Given this list of marker genes APC, UFD1, CHRNG, SYT2, DCHS1, NDUFB3, COA8, GLI3, INPP5E, YY1, COL25A1, MED12, SAMHD1, ANOS1, AFF4, RAD51C, SOX4, DPF2, ZNF423, GSN, CHRNE, SUFU, NDUFS7, RERE, PIBF1, SNAI2, ZFHX4, SLC6A8, MYCN, AIP, ATP5F1A, COMT, SLX4, MYO9A, HRAS, SLC25A1, TYMP (NCBI Gene Id 4334), CBY1, ZNF407, PDE4D, RAD51, RSPRY1, NDUFS2, MEN1, SMAD4, KIF11, SLC30A9, ARID1B, MT-TL1, RRAS, FILIP1, LSM11, TBCK, SECISBP2, TUBA1A, VAMP1, PDE6D, PEX3, COX10, ANXA11, PIEZO2, RPL8, MYMK, BCAS3, ADNP, TMEM107, JMJD1C, AARS1, DNM1 (NCBI Gene Id 1759), CNKSR2, SMC1A, AKT1 (NCBI Gene Id 207), TGIF1, TGFB2, TMEM67, KRAS, CAPN15, DGUOK, DIS3L2, FGF10, MECP2, CBL, NOTCH2NLC, PLCB4, SMARCC2, RPS28, SLC5A7, DALRD3, ADPRS, MPV17, TENM3, DHDDS, PSMD12, TET3, ANKRD11, GABRA5, CYC1, PUF60, COLQ, NIPBL, PARS2, GRIN2D, SMARCE1, KCNC2, NDUFV2, MAFB, GLE1, LMX1B, KCNA2, CDC42BPB, SLC3A1, YAP1, IREB2, OFD1, ABHD5, LMOD3, ZNF462, RFWD3, ATP1A2, SLCO2A1, RPS19 (NCBI Gene Id 8378), MRPS34, AGRN, PROK2, AUTS2, CAPRIN1, FBXO28, SLC12A6, BRCA1, PIGL (NCBI Gene Id 9487), PEX19, NOP56, PYROXD1, SQSTM1, RNU12, ISCU, HMGB3, CPLX1, FOXL2, KMT2B (NCBI Gene Id 9757), KIF21A, SPRY4, BRPF1, NDUFAF2, EP300, SCN1A, GATA1, NAA10, FGF17, RB1, SMARCA2, CPLANE1, TUBB2B, TWIST1, WDR35, SYNJ1 (NCBI Gene Id 8867), PEX12, GCK, PAX6, RPL15, FANCF, PRR12, FANCM, PUM1, MYH3, FGFR2, EDEM3, PRDX3, RNASEH2C, NFU1, FOXP1, MYF6, NDUFAF4, FANCB, DVL3, CTCF, FOXC2, SURF1, COLEC11, NDUFS1, PEPD, TIMMDC1, MID1, GABRB2, RILPL1, FANCD2, C1QBP, MAP2K1, TGFBR1, LZTR1, ZSWIM6, DHCR7, PDZD8 (PDZ domain containing 8), TBK1, PEX11B, SLC1A2, NTRK2, SALL4, SF3B4, TH, NDUFA6, HCN1, PHOX2B, IDS, ARID2, TBC1D2B, PIGQ, SMARCB1, WDR11, ODC1, NSD2, PPP3CA, IDUA, TMEM218, PEX10, CDC42, ITCH, CDH23, ARMC9, LONP1, SETD5, NSUN2, KIF1B (kinesin family member 1B), HACE1, TARDBP, MYL2, KATNIP, ATP5F1D, MICU1, RPS26, CELF2, IL17RD, UBE2T, GIPC1, GMPPA, ALX1, HPGD, SCN3A, WNT5A, SCN8A, EED, PPP1CB, ATPAF2, PTPN11, RBCK1, RASA2 (RAS p21 protein activator 2), LGI4, DUSP6, TCOF1, EXOC8, REV3L, TPM2, TACR3, RPL35, RREB1, FOXRED1 (FAD dependent oxidoreductase domain containing 1), DOK7, NDUFAF3, TMEM43, CSNK2A1, RIT1, CCDC141, TMCO1, KITLG, MAD2L2 (mitotic arrest deficient 2 like 2), RPL27, PROKR2, CCDC28B, PEX6, KIFBP, NDUFS8, TMEM138, SLC18A2, GATA3, SOX10, DDX59, MAPK1, SMS, IFT74, FOXC1, CHAT, SKI, ADAMTS15, KAT6A, TMEM126B, COL3A1, PEX2, RPS17, MINPP1, PHYH, NPTX1, NECAP1, BAP1, TLK2, SPRED1, ERBB2, FANCE, LRP4, FAT4, NEFL, HDAC8, LMNA, ANKLE2, KIAA0586, DLAT, BRCA2, IPO8, FGFR1, TEFM, MYF5, PEX13, TK2, PHF6, NDUFS6, SEPTIN9, CHD8, IER3IP1, SZT2, FARS2, SIAH1, KDM1A, COQ2, NDUFB9, PEX16, ATP6V1A (ATPase H+ transporting V1 subunit A), PURA, SEMA3E, PREPL, ATP1A3, SYNE1, IFIH1, RPS24, FGFR3, CACNA1B, SMARCA4, RRM2B, PEX1, CHRNB1, MT-ND3, KDM6A, NDUFS3, NDUFA1, RPS27, SGPL1, RAD21, COL1A2, BDNF, RNASEH2B, ALDOA, GFER, PHOX2A, RPS20, MT-ND2, ATP5F1E, NOVA2, RNASEH1, POGZ, TFE3, ZNF699, PDX1, MASP1, EEF1A2, TMEM231, SCO2, JARID2, HLA-DRB1, FEZF1, FGFRL1, MTSS2, TNPO3, KIAA0753, SBF2, MT-TL2, KBTBD13, KIF5A, FZR1, WFS1, RYR1, H4C3, INS, ERI1, HUWE1, POLG2, UNC80, ARHGEF2, MTTP, TCF12, RPS7, SLC19A3, ARVCF, NUBPL, TSR2, RALA, FBN1, ITPR1, CEP290, SLC52A3, WT1, GABRG2, HOXB1, SLC38A3, RPGRIP1L, PLXND1, PRMT7, ADA2, DCC, ARL13B, RBM8A, KMT2D, FANCI, QRICH1, ARL3, DDC, SUCLA2, MUSK, TUBB3, MITF, GRM1, FGF12, FBXL3 (NCBI Gene Id 26224), OPA1, MRAS, MT-TN, GPC4, ADAR, ERCC4, PIGG, AK9, SLC18A3, MAF, TP63, TRAK1, GFPT1 (glutamine--fructose-6-phosphate transaminase 1), PLOD1, PIGA, DPAGT1, KLHL41, ALX3, BCOR, GNAI3 (NCBI Gene Id 2773), HECW2, ROR2, TRIM44, TRAF7, PAX7, POLR1A, RAB3GAP1, ERBB3, KMT2A, PPP2R5D, ZMYND11, CLTC, FGF8, FAM149B1, CHD4, MYPN, AFG3L2, STAMBP, MYOD1, SPRED2, RPL18, TBC1D20, SOST, MYMX (NCBI Gene Id 101929726), NELFA, CREBBP (CREB binding protein), PDGFRB, NDUFV1, UGDH, WDR73, BCS1L, GABBR2, SEC24C, MT-ND1, SDHA, NDNF, FANCG, HK1, NDUFAF1, TAF6, PEX5, VCP, FDX2 (NCBI Gene Id 2143), MAP2K2 (NCBI Gene Id 85511), NALCN, NDUFB10, HS6ST1, ZEB2 (zinc finger E-box binding homeobox 2, NCBI Gene Id 9839), ZC4H2, FLNA, SOS2, SETBP1, STAT3, PACS2, FANCL, B3GLCT, TRPM3, CDK8, RNASEH2A, CCDC47, NDUFS4, DNM1L, HIRA, SHANK3, CRELD1, CACNA1A, GMPPB (NCBI Gene Id 29925), SUCLG1, DNM2, FANCC, LAMB2, CDK13, CCDC115, MAPRE2, COQ8A, PDHA1, TBX1, NPHP1, RRM1, ECEL1, KCNJ11, ABCC8, FZD2, XRCC2, AHDC1, B9D2, SIX2, CERT1, AP3B2, TYMS, HESX1, EDNRB, EDN1 (endothelin 1), NRAS, LETM1, TCTN2, ACTG1, GP1BB, BRAF, UBR7, RAPSN, HNRNPK, ACKR3, GNB2, FANCA, ESCO2, FAR1, ATXN3, TREX1, CTBP1 (NCBI Gene Id 1487), GBA1, CYFIP2, NDUFB11, LYRM7, GABRA2, PABPN1, KCNB1, ACBD5, FLRT3, RPL11, FBLN5, NDUFA11, SHOC2, CHD7, ZMIZ1, HYLS1, P4HA2, COL2A1, DVL1, THUMPD1, HEATR3, GPRASP2, NARS2, ACTL6B, MT-ATP6, NF1, LMO1, IARS2, TOP3A, EARS2, NEB (nebulin), POLRMT, CHN1, MED13L, MRPS28, PHIP, ASCC3 (NCBI Gene Id 63921), CNTNAP1, LRP12, JAG2, CEP104, WWOX, RPS10, TCTN3, COLEC10, PALB2, FUS, BBS1, RPL26, ATRX, TWNK, BRIP1, CNP, HLA-B, NEUROG1, ZBTB20, TAMM41, PLXNA1, DNA2, CC2D2A, TRIO (trio Rho guanine nucleotide exchange factor), MTMR14, FBXL4, MKS1 (NCBI Gene Id 54903), ATP6V1B2, NAA80, ANO10, CDH11, CHRNA1, HNRNPA2B1, PRPS1, RPL35A, COL13A1, SYNGAP1, MYH8, MID2, DBH, RAF1, ALDH18A1, TAF8, AEBP1, MED25, DARS2, YWHAG, TUBB6, BRD4, SLC13A5, ALK, ALG14, FGD1, TSPOAP1, SOX11, YARS2, VARS2, FOXG1, SMC3, TBC1D24, IGF1, TOGARAM1, NOTCH3, AHI1, ROBO1, RPS29, UBE3B, SMARCD1, CHRND, ANAPC7, SPECC1L, KCNN2, DHX37, WNK3, PIK3CA, PSAP, ARID1A, MGME1, RPL5, KDM5B, SCN4A, POLG, RNU7-1, FHL1, CLCN3, CFL2, ALG2, RPL9, MYH2, TPM3, TMEM216, MTRFR, ACTB, RRAS2 (NCBI Gene Id 22800), CDK19, SPR, LIG3, HMBS, PEX26, KANSL1, LIN28B, RPS15A, TOR1A, UBA5, NXN, ZIC1 (NCBI Gene Id 7545), ATG7 (autophagy related 7), ARL6, CSPP1, GLI2, ASXL2, MYO18B (NCBI Gene Id 84700), LIG4, PEX14, SYNE2, U2AF2, TFAP2B, GRIA3, TTR, SLC17A5, SF3B2, NOG, NDUFAF5, SC5D, SLC25A4, PIK3R2, TYR, NUS1, TFAP2A, HSPG2, CACNA2D1, TMEM237, PTS, ATP5MK, CEP41, BPTF, MARK3, MBTPS2 (membrane bound transcription factor peptidase, site 2), MT-ATP8, UBA1, PPP1R12A, COL9A3, PEX7, ACTA1, MAP3K7, TCTN1, BRCC3, PLEC, STAC3, EFEMP1, TMLHE, B9D1, GNPNAT1, SEMA3A, SNAP25 (synaptosome associated protein 25), NDUFAF8, BIN1, PAX3 (NCBI Gene Id 5077), TGFB3, MED12L, EMD, PACS1, NGLY1, NUTM2B-AS1, KCNH1, TTN, ELN, SOS1, CHCHD10, RPL31, ERF, PTPN22, FLI1, PAH, CEP120 (centrosomal protein 120), EPG5, SLC6A9, here is a description of the gene set: studied in species Homo sapiens The upper eyelid margin is positioned 3 mm or more lower than usual and covers the superior portion of the iris (objective); or, the upper lid margin obscures at least part of the pupil (subjective). Human Gene Set: HP_PTOSIS Ptosis